The following is a description of a gene set: Mouse Gene Set: RAMPON_ENRICHED_LEARNING_ENVIRONMENT_LATE_UP An enriched environment is known to promote structural changes in the brain and to enhance learning and memory performance in rodents. To better understand the molecular mechanisms underlying these experience-dependent cognitive changes, we have used high-density oligonucleotide microarrays to analyze gene expression in the brain. Expression of a large number of genes changes in response to enrichment training, many of which can be linked to neuronal structure, synaptic plasticity, and transmission. A number of these genes may play important roles in modulating learning and memory capacity. from publication Rampon C, Jiang CH, Dong H, Tang YP, Lockhart DJ, Schultz PG, Tsien JZ, Hu Y (PMID 11070096) Genes up-regulated in the brain cortex of mice that were exposed to an enriched learning environment for 2 or 14 days. studied in species Mus musculus, and this is the list of marker genes: Dnpep, Vldlr, Cttn, Psmb3, Xpnpep1, Sez6, Polr2c, Tbca, Dlg4, Map4, Btf3 (NCBI Gene Id 73444), Calm3, Calb2, Coro1a, Dctn5 (dynactin 5), Usp21, Dhx32, Cdh2, Clpp, Zic1, Xbp1